The following is a description of a gene set: Any process that modulates the frequency, rate or extent of bile acid metabolic process. species: Mus musculus Mouse Gene Set: GOBP_REGULATION_OF_BILE_ACID_METABOLIC_PROCESS, and this is the list of marker genes: Stard4, Malrd1, Prox1, Ces1f, Ces1g, Abcb11, Ces1h (NCBI Gene Id 75704), Cyp7a1, Fgfr4, Ces1e, Sirt1, Ces1c, Ces1b, Star (NCBI Gene Id 52131), Ces1d, Kit, Fgf15 (NCBI Gene Id 14170), Ces1a (NCBI Gene Id 244595), Pank2, Nr1d1